Given this list of marker genes Bloc1s5, Cyp19a1, Gosr2, Slc30a2, Cpa3, Syt5, Snca, Atp6v0e2, Mtmr2 (NCBI Gene Id 77116), Slc18a1, Pick1, Syt12, Ap3m2, Slc35f1, Rab11a, Atp6v1a, Slc17a6 (solute carrier family 17 (sodium-dependent inorganic phosphate cotransporter), member 6), Snap25, Cops4 (NCBI Gene Id 52442), Atp6ap2, Trappc4, Grin2b, Pcsk1, Madd, Mal2, Mt3, Cideb (NCBI Gene Id 68665), Rab10, Spg21, Ap1g2, Rab7, Resp18, Ap1s1, Aph1a, Borcs5, Entpd1, Cops5, Slc30a8, Th, Npy1r, Atp2b1, Syt4, Rab8b, Syngr3, Iqsec1, Tprg1l, Syt10, Vma21, Sec24b, Kcnq1, Gabra2, Clcn5, Ovgp1, Kif1a, Atp6v1g1, Tmem168, Dpysl3, Scap, Ece2, Syp, Sorl1, Nptx1, Itpr3, Oprd1, Il33, Atp6ap1, Rab26, Stxbp5, Clrn1, App, Lin7a, Sypl1, Vamp3, Slc17a5, Igf2r, Svop, Dmxl2, Septin1, Stx17, Ncstn, Dnajc5, Vgf, Mctp1, C1qtnf5, Stx6, Rab13, Bin1, Sec24d, Snap91, Nrsn1, Prrt1, Unc13a, Otof, Slc6a7, Scgn, Slc40a1, Chp1, Dlg4, Akap7, Sytl5, Sv2c, Tmem30a, Ceacam1, Lin7c, Slc2a4, Cadps2, Synrg (synergin, gamma), Apc, Scamp1, Sec23a, Tmem184a, Atp6v0d1, Klhl12, Rab4a, Rnf112, Lin7b, Syt6, Sar1a, Atp6v1f, Vps33b, Atr, Slc6a2, Rab14, Cttnbp2, Ptprn, Atm, Sytl4, Ston1, Dgki, Phaf1 (phagosome assembly factor 1), Atp8a1, Slc18a3, Ston2, Eef1ece2, Ntf5, Dnm1l (dynamin 1-like), Stx12, Plekhf2, Sec23ip, Rabac1, Laptm5, Tmem163, Ptprn2, Rab12, Syt11, Cbarp, Syngr1, Srebf2, Gria1, Dlg2 (discs large MAGUK scaffold protein 2), Sar1b, Vdac3, Sytl3, Tafa4, Slc35g2, Syngr2, Unc13d, Rab40c, Unc13b, Spred2, Cdk16, Vps45, Clba1, Ccdc88a, Cltb, Clcn4, Sytl1, Bgn, Tor1a, Syngr4, Yipf2, Clta, Itpr1, Kif1b, Syn2, Atp6v0a4, Dbi, Ap1m2, Syndig1, Syt8, Hspa8, Anxa5, Atp6v1d, Stx7, Pebp1 (phosphatidylethanolamine binding protein 1), Atp6v1g3, Htr7, Rab11b, Gipc1, Ap4b1, Slc10a4, Gopc, Galnt15, Btbd8, Slc5a7, Pdyn, Stx1a, Slc6a17, Ap1g1, Rab3b, Bcl2l1, Lamp5, Gabbr1, Calm2, Sgta, Fgfrl1, Ap1s2 (adaptor-related protein complex 1, sigma 2 subunit), Cav2, Crisp1, Vdac1, Ica1, Rab40b, Rab5b, Dmbt1, Car4, Slc2a3, Atp6v1b1, Atp6v0c, Sypl2, Atg9a, Calm3, Nrsn2, Tgoln1, Exoc3l, Arfgef3, Rab35, Aftph, Gad2, Lyz1, Rab6a, Ube3a, Rab27a, Slc32a1, Phf24, Pcsk2, Amph, Sema4c (NCBI Gene Id 98332), Rab3c, Gnas, Disc1, Doc2b, Ngf, Lamp1, Dtnbp1, Uso1, Sphk1, Vamp1, Ap2m1 (adaptor-related protein complex 2, mu 1 subunit), Ap1m1, Crisp3, Vti1a, Crispld2, Itpr2, Atp6v0a1, Slc30a5, Dlg1, Pde4b, Sec23b, Slc17a9, Clcn3, Cpe, Ddc (dopa decarboxylase), Slc4a8, Stx16, Fgfr3, Atp6v1e1, Scamp5, Trpm7, Septin6, Znrf1, Hap1, Mff, Mylk2, Grin2a (NCBI Gene Id 14811), Dnm1, Bace1, Atp6v1c1, Bloc1s6, Sspn, Picalm, Syt13, Septin4, Slc9b2, Atp6v1h, Bloc1s3, Gria2, Erg28, Yipf3, Myo5a, Nkd2, Furin, Penk, Syn3, Rassf9, Cadm1 (NCBI Gene Id 80622), Sfta2, Kcnk9, Unc13c, Ap2a1, Syt7, Grin1, Bdnf, Slc6a9, Slc30a3, Atp7a, Kif3c, Slc35d3, Brsk1, Rab3d, Sh3glb1, Rac1, Rogdi, Arpc2, Sec16a, Trim9, Sec31a, Sec13, Abcc8 (NCBI Gene Id 330527), Wfs1, Marcksl1, Slc2a8, Park7, Tmed9, Ptpn5, Vdac2, Sec22b, Ap3s2 (NCBI Gene Id 11778), Scg3, Syt17, Adam10, Myrip, Sptbn2, Sec16b, Atp6v1g2, Syt3, Tmem230, Shh, Ppt1, Snapin, Cplx3, Prkn, Cnst, Rab3a, Syt2, Ap1b1, Rab11fip5, Chga, Vti1b, Rab8a, Calm1, Rab5a, Nrgn, Exoc4, Rph3al, Kirrel3, Ptprs, Aph1c, Slc22a2, Vamp2, Lyz2, Dmd, Cltc, Aph1b, Tmed10, Cln3, Psen1, Atp13a2, Kcnc4, Sprr2a3, Rab5c, Map6, Psen2, Hck (NCBI Gene Id 99093), Slc17a8, Aqp2, Ap2a2, Syt1, Sntb2, Gpr151, Yipf1, Sytl2 (NCBI Gene Id 83671), Lrrk2, Pam, Snap29, Sec24c, Abca12, Ap1s3, Ankrd27, Fgfr4, Syn1, Rph3a, Pef1, Sprr2a1, Rab4b, Sort1, Pi4k2a, Igf1, Dync1i1, Erc1, Sh3gl2 (NCBI Gene Id 319329), Mctp2, Septin8, Anp32e, Prrt2, Sec24a, Ap1ar, Ndel1, Syt9, Ntf3, Ppfia2, Nts, Synpr, Steap2, Oprk1, Lgi3, Spx, Sv2b, Dbh, Pdcd6, Nmnat2, Slc18a2, Slc17a7, Bsn, Drd2, Azin2, Wdr7, Septin5, Atp6v1b2, Sec31b, Rab2a, Srebf1, Slc18b1, Rab27b, Slc2a13, Mme, Sv2a (NCBI Gene Id 99706), Syt15, Doc2a, here is a description of the gene set: Any of the vesicles of the constitutive secretory pathway, which carry cargo from the endoplasmic reticulum to the Golgi, between Golgi cisternae, from the Golgi to the ER (retrograde transport) or to destinations within or outside the cell. Mouse Gene Set: GOCC_TRANSPORT_VESICLE species: Mus musculus